The following is a description of a gene set: from publication Scian MJ, Carchman EH, Mohanraj L, Stagliano KE, Anderson MA, Deb D, Crane BM, Kiyono T, Windle B, Deb SP, Deb S (PMID 17982488) studied in species Homo sapiens When normal cells come under stress, the wild-type (WT) p53 level increases resulting in the regulation of gene expression responsible for growth arrest or apoptosis. Here we show that elevated levels of WT p53 or its homologue, p73, inhibit expression of a number of cell cycle regulatory and growth promoting genes. Our analysis also identified a group of genes whose expression is differentially regulated by WT p53 and p73. We have infected p53-null H1299 human lung carcinoma cells with recombinant adenoviruses expressing WT p53, p73 or beta-galactosidase, and have undertaken microarray hybridization analyses to identify genes whose expression profile is altered by p53 or p73. Quantitative real-time PCR verified the repression of E2F-5, centromere protein A and E, minichromosome maintenance proteins (MCM)-2, -3, -5, -6 and -7 and human CDC25B after p53 expression. 5-Fluorouracil treatment of colon carcinoma HCT116 cells expressing WT p53 results in a reduction of the cyclin B2 protein level suggesting that DNA damage may indeed cause repression of these genes. Transient transcriptional assays verified that WT p53 repressed promoters of a number of these genes. Interestingly, a gain-of-function p53 mutant instead upregulated a number of these promoters in transient transfection. Using promoter deletion mutants of MCM-7 we have found that WT p53-mediated repression needs a minimal promoter that contains a single E2F site and surrounding sequences. However, a single E2F site cannot be significantly repressed by WT p53. Many of the genes identified are also repressed by p21. Thus, our work shows that WT p53 and p73 repress a number of growth-related genes and that in many instances this repression may be through the induction of p21. Cell cycle genes down-regulated in H1299 cells (lung cancer) after overexpression of either P53 or P73. Human Gene Set: SCIAN_CELL_CYCLE_TARGETS_OF_TP53_AND_TP73_DN, and this is the list of marker genes: CKS2, RAN, CDC25B, CDC20, GTSE1, CCNB1, KIF23, MAPRE2, CDKN3, CDC25C, TPX2, MCM7, CDK2, KIF22, MYC, CCNF, DTYMK, G0S2, MCM6, UBE2C, CCNA2, AURKA